Given this list of marker genes TNFRSF14-AS1, ASGR1, CLMN, GCKR, GLYAT, A1CF, TMEM176B, SLC25A20, GGCX, ST3GAL1, GSTA5, TRIM50, C1QTNF4, SULT2A1, TPM2, C6, MTUS1, CLCNKA, ARHGAP4, KLKB1, GLYCTK, GLI4, SLC22A18AS, FRK, NGEF, MCF2L, SLC6A12, CLRN3, CIDEC, LINC02906, CLSTN3, CYP4X1 (cytochrome P450 family 4 subfamily X member 1), GRB14, HLF, MCF2L-AS1, NEAT1, MUC20-OT1, NR1H3, RAB11FIP4, AMT, PWWP3B, CHIA, MAP3K13, SLC22A18, LY6D, CYP3A7, ONECUT1, HGD, CXCL1, SPINK1, LYRM9, APBB1IP, KCNK5, EPHA1, LINC00626, MST1, LINC01320, SAA3P, C2orf72, MMP19, KCNJ16, SERPINA5, LINC02649, GCGR, LCA5L, NFKBIZ (NCBI Gene Id 64332), OXER1, SNORA47, LINC00598, COL7A1, BLNK, FGD3, CXCL13, RORA, ITGA10, ENSG00000284948, GUCY1A1, NEURL3 (neuralized E3 ubiquitin protein ligase 3), CYP21A2, ABLIM2, C1orf21, STK19, CDH16, NXPH4, PRODH2, CLDN16, ASB13, CYP2B6, MATK, LINC02770, LINC00844, LPIN3, SLC22A9, GRM3, EPHX2, XAF1, PPP1R3C, SEC14L4, AKR7L, CACNB2, FGB, MUC20, ARSL, PTGFR, ST6GAL1, SPP1, LINC01667, TTBK1, AUTS2, ACSF2, PON1, CYP3A5, EHF, ALDH4A1, ENGASE, TMEM150A, ATP8B3, CHRD, MAOB, HAO1, ASL, SLC5A9, EFNA1, CRYM, LINC00923, TMEM198B, C1orf115, LINC00526, TDO2, RAB37, SCARF1, RGN, DNAH1, CA9, ACAA1, BATF2, FGA, GJB1, GCHFR, H6PD, GARS1-DT, CLEC18B, ADAMTS13, MALAT1, GLDC, CCDC18-AS1, SEC31B, ABCG8 (NCBI Gene Id 64241), SMLR1, NTN5, HIP1R, GPD1, SNAI3-AS1, SLC6A16, ORM2, ABCA5, CEACAM1, BAAT, CIDECP1, NHERF4, IGLL1, HSD17B3, LINC01719, ADRA1A, C1orf54, TMEM176A, NUDT7, TGFBR2 (transforming growth factor beta receptor 2), LINC00973, SERPINA1, GSTA1, ENSG00000290654, SCX, LINC00685, DDC, PLK5, ABAT, CYTIP, NAT8, ITPR2, PRODH, PDZK1, TMEM100, LDHD, PHKA2-AS1, FGD4, HPN, LINC02027, SLC49A3, NR1H4, SLC2A4, PCSK4 (NCBI Gene Id 54760), PAG1, ABCB1, ANG, APOC1, PLIN5, S100A12, GTF2IRD2, ALDOB, CTSH, RNF180, VEGFA, CHRDL2 (chordin like 2), ALDH1L1, VEPH1 (NCBI Gene Id 79674), CADM2, PC, COL5A3, ENO3, C4A, ALB, CTDSP2, NABP1, POU5F1, ITIH4, PCYT2, SPOCK3, ETNPPL, TRIM36, DPP4, C5AR1, SF1, MYO7A, C3orf85, CFI, GLRX, SMIM10L2B, ORM1, MAN1C1, GADD45G, SPX, F13B, INSIG1, FOLR3, ARHGEF10L, CCL15, DNAI1, PPP1R16A, CYP2C8, KANK1, FABP1, PGLYRP2, GAS2 (growth arrest specific 2), AFM, SLC23A1, PFDN6, SLC28A1, BAIAP2L2, ABCB4, RASSF4, HMGCS2, MOGAT1, PDE11A, ADH6, PAQR6, RORC, DPT, HAO2, EFEMP2, AQP7P1, SLC17A4, AFMID, C2orf92 (NCBI Gene Id 730797), NAT8B, TMEM238, MEGF8, GAS6-AS1, ATP5F1B, PIK3C2G, ANKRD24 (ankyrin repeat domain 24), DCAF8, NRBP2, NLRP1, ZBED3, MCCC1, PNPLA3, COL28A1, RAB17, ABCC9, LRRK2, ARID5A, DOCK4, CYP4F3, INSR, SLC2A14, C1QTNF6, UGT2A3, HAPLN3, RASL10A, EVPLL, ASGR2 (NCBI Gene Id 433), DAND5, LINC03007, HNF1A-AS1, SELENBP1, HHEX, HP, CLIP3, RNF207, WNT11, CRB3, KRTAP3-3, GARIN1B, SNORA73A, ACY3, HNF1A, SLCO4C1, PTPRN2, PDE8B, LINC01341, MMAA, PTK2B (NCBI Gene Id 5748), FZD8, MIA2, A1BG, RNPC3, GGT7, SNAP47, REEP6, NPY6R, TTC39A, IQCN, ACACB (acetyl-CoA carboxylase beta), MAP7D2, IL18R1, ERBB3, APOE, RAB26, PAIP2B, ELMO1, ODAM, ODAD3, MROH2A, COL27A1, TMEM266, ABCC6, SOX6, LPIN1, ACMSD, CARMN, RAPGEF4, MLXIPL, CISH, F10 (coagulation factor X), PLCXD1, TRPV1, CIDEB, PNPLA7, C3orf18 (chromosome 3 open reading frame 18), S100A8 (S100 calcium binding protein A8), LINC00659, CFAP70, F5, ACSM2B, LMNTD2, SEC16B, SEMA4G, SLC23A3, SGK1, THSD7A, RANBP3L, MME (NCBI Gene Id 4311), FSIP2, GFI1B, NAMPT, ACAD11, KHK, RBP5, KIFC2, DHRS3, FZD4, SRP14-DT, NUDT16, TCIM, DCN, SULT1C2, TEF, KLC4, SP100, TM4SF4, ZBED3-AS1, RGS7BP, GOLT1A, COL3A1 (collagen type III alpha 1 chain), ID2B, CPEB3, VSX1, HOXD13, AQP4, SLC6A10P, UPB1, DNHD1, FAM153A (family with sequence similarity 153 member A), GDA, CCDC198, COLCA1, ACAN, WIPF3, SLC40A1, ACSM3, NEB, ACSS1, CYP4A11, MMP7, CREB3L3, MUC15, GPT, PROX1, UCN, AGBL2, AGT, GBA3, AMY1A, SYT7, PDK2, SORBS1 (sorbin and SH3 domain containing 1), ETV1, TRIM15, ABCC6P1, TTLL3 (NCBI Gene Id 26140), DLG2, LIPC, LINC01569, PPP1R3B, LINC00870, PLA1A, ACSM5, PACSIN1, BAIAP3, RAB6C-AS1, DIPK1B, ANKK1, GATM, C5orf46, SGK2, SOX13, CCER2, SEPTIN8, HSF4, CCL14, SMPDL3A, ZNF318, C11orf86, ATP2B2, TDRG1, DCDC1, RNF43, TM7SF2, DGAT1, TAMALIN, SERPINF1, SPSB1, HSD11B2, SLC2A2, LINC00574, OAF, GULP1, MYO15B, here is a description of the gene set: Transcriptome of human HepaRG hepatocellular carcinoma liver progenitors in responses to a WNT3A-enriched microenvironment and dissection of pathways dependent on _-catenin and/or blocked by the SFRP-like Wnt inhibitor FZD8_CRD. from publication Mebarki S, Désert R, Sulpice L, Sicard M, Desille M, Canal F, Dubois-Pot Schneider H, Bergeat D, Turlin B, Bellaud P, Lavergne E, Le Guével R, Corlu A, Perret C, Coulouarn C, Clément B, Musso O (PMID 27191501) Methods: Liver progenitor cells were incubated in a WNT-enriched microenvironment for 72hrs (200 ng/ml mouse recombinant purified Wnt3A from R&D Systems). Gene pathways dependent on downstream _-catenin were studied by _-catenin knockdown with specific siRNA. Gene pathways blocked by extracellular SFRP-like Wnt inhibitors were studied by co-incubating cells with recombinant purified FZD8_CRD (300 ng/ml, from R&D Systems). Independent culture experiments performed in triplicate include untreated cells or cells incubated with scrambled siRNA or with _-catenin-specific siRNA or with FZD8_CRD, alone or in combination with Wnt3A. In the absence of Wnt in the microenvironnment, soluble FZD8_CRD may dimerize with other cell surface FZD_CRD domains. Human Gene Set: MEBARKI_HCC_PROGENITOR_FZD8CRD_DN studied in species Homo sapiens